Given this list of marker genes PUF60, SIX5, KMT2D, EYA1, SIX1, RPL10, here is a description of the gene set: A branchial cyst is a remnant of embryonic development resulting from a failure of obliteration of a branchial cleft and consists of a subcutaneous cystic mass. Cysts are located anterior or posterior to the ear or in the submandibular region. Branchial cyst studied in species Homo sapiens Human Gene Set: HP_BRANCHIAL_CYST